Given this list of marker genes INHBB, ALOX5AP, CRHBP, RASAL1, FOS, RYR1, TUBA1A, MEF2C, NEUROD2, MICU2, NFATC2, ADCY1, MICU3, SMPD1, LCE1D, RASGRP2, CPNE8, CPNE4, MICU1, RASA4B, CARF, RYR3, SLC25A24, KCNQ3, CACYBP, CLIC4, HPCA, EDN1, JUND, PPIF, GUCA1A, MCOLN1, LGMN, SLC25A23, ITPKA, CPNE5, CHP2, JUNB, CPNE2, CPNE7, FOSB, IQGAP1, ITPKC (NCBI Gene Id 80271), DPEP1, ABCC9, SYT1, KCNB1, CAMK2D, ADCY8, ITPKB, WNT5A, KCNH1, ECT2, EEF2K, JUN, PRKAA2, NCSTN, ADGRV1 (NCBI Gene Id 84059), CPNE6, ADD1, ALOX15, PKD2, AKR1C3, CAPN3, CPNE3, CPNE1, TRPM2, ENDOG, BRAF, CPNE9, PRKAA1, ACER1, PLCG2, RASA4, NRXN1, NLGN1, SCN5A, GUCA1ANB-GUCA1A, MEF2A, ASPH, here is a description of the gene set: Human Gene Set: GOBP_CELLULAR_RESPONSE_TO_CALCIUM_ION studied in species Homo sapiens Any process that results in a change in state or activity of a cell (in terms of movement, secretion, enzyme production, gene expression, etc.) as a result of a calcium ion stimulus.